Given this list of marker genes CRYAB, MT-TL2, LRP12, MT-TE, COL6A1, PNPLA2, TRAPPC11, COL12A1, LDB3, COL6A2, MPV17, MT-TL1, DYSF, MYOT, ABHD5, PLEC, TK2, MLIP, MT-TN, ANO5, PYGM, RILPL1, VCP (valosin containing protein), NOTCH2NLC, GIPC1, NEB, COL6A3, here is a description of the gene set: Progressive proximal muscle weakness Lack of strength of the proximal muscles that becomes progressively more severe. species: Homo sapiens Human Gene Set: HP_PROGRESSIVE_PROXIMAL_MUSCLE_WEAKNESS